The following is a description of a gene set: studied in species Homo sapiens Genes up-regulated in B lymphocytes: untreated versus anti-IgM for 1h. Human Gene Set: GSE41176_UNSTIM_VS_ANTI_IGM_STIM_BCELL_1H_UP from publication Shinohara H, Behar M, Inoue K, Hiroshima M, Yasuda T, Nagashima T, Kimura S, Sanjo H, Maeda S, Yumoto N, Ki S, Akira S, Sako Y, Hoffmann A, Kurosaki T, Okada-Hatakeyama M (PMID 24833394) The activation signaling of transcription factor nuclear factor-kB (NF-kB) plays central role for immune system. One of key kinase mediating this pathway is TAK1 in adaptive and innate immunity. However, role of TAK1 in B cell receptor signaling is still unclear. To know effects of TAK1-deletion on the gene expression induced by anti-IgM, we performed the time course analysis in comparison of wild type with TAK1-deleted splenic B cells., and this is the list of marker genes: KCNE5, SLC43A3, OR7E156P, SLAMF1, RAP1B, PLAUR, ACSL5, NAMPT, HCAR3, CYP27B1 (cytochrome P450 family 27 subfamily B member 1), CHST2, BTG3, IL6, BATF, CEMIP, FJX1, IL36G, FNDC3B, AGRN, MMP7, IER3, CEBPB, PTGS2, DUSP2, LIMK2, ANKRD7, HSPA2, INHBA, CCL4, UPB1, CXCL3, TNFAIP8, TTLL4, LILRA3 (NCBI Gene Id 11026), SOS1, SPAG1, SERPINB1, SLC11A2, LDHAL6B, SYN1, EHD1, LAMB3, SMPDL3A, IL23A, CXCL1, NFKBIE, TREM1, SMS, NFKBIB, CXCL6, ACSL1, HAS1, ETS2, RHBDF2, MYO1B, WNT5A, AMPD3, TNFAIP6, MARCKS, LYN, CYTH2, GLYR1, CHP2, NINJ1, PCOTH, SOCS3, TANK, MYL1, NFE2L1, CXCL8, ADGRE1, TNIP2, TRAF1, MT1F, PLAGL2, BCL2L2 (NCBI Gene Id 599), YRDC, YIPF6, MTF1, TRIP10, ZC3H12A, KCNJ2, TLR2, TFPI2, IER5, IL7R, VAV1, SLC7A11 (solute carrier family 7 member 11), TNFRSF1B, FOSL2, CD80, ELL, EBI3, TPST1 (tyrosylprotein sulfotransferase 1), UBE2Z, DNAJB5, CHRM4, IL1B, FRZB, PIM2, HEY1, NUP98, PTX3, GADD45B, CCL20, NFAT5, CLIC4, SLC2A6, EWSR1, DNAJA1, SPRED2, PROCR, CYP3A5, FFAR2, SOCS2, GPR137B, NFKBIA, BCL2L14, SLC12A5, KRT12, PRSS12, ENTPD7, IL19, C1QTNF1, NCOR2, MAP3K4, CELA3A, CXCL2, IL1A, CLCN2, TBK1, SLC19A3, G0S2, NFKB1 (NCBI Gene Id 4790), PANX1, UPP1, SRC, MYO6 (NCBI Gene Id 4646), HOXA1, TOM1, SOD2, BHLHE41, PDSS1, PPIF, PTAFR, RNF115, ZBTB17, PLAT, TNFRSF9, PRDM5, HCK, UGCG, SUSD6, IL15RA, MICALL1, GNG12, SMG9, NDP, CASP4, TNIP3, STAT4, IL12B, TRIP11, DLC1, ADGRL4, ADM, BCL3, TLCD3A, C5orf15, UPK1A, LPAR1, TNIP1 (TNFAIP3 interacting protein 1), MXD1, GRINA, ETV5, HELLS, RAPGEF4, DUSP5, TRIB1, DNTTIP2, PRR16, KCNN4, IL33, WTAP, FEZ1, SLC12A1, REEP1, MAMLD1, CA14, PRRX1, SLC16A6, FPR2, NCAM2, MT1M, ICAM1, PDPN, SIGLEC9